The following is a description of a gene set: Human Gene Set: HP_FLAT_CORNEA studied in species Homo sapiens Cornea plana is an abnormally flat shape of the cornea such that the normal protrusion of the cornea from the sclera is missing. The reduced corneal curvature can lead to hyperopia, and a hazy corneal limbus and arcus lipoides may develop at an early age. Flat cornea, and this is the list of marker genes: RFC2, METTL27, BUD23, STX1A (NCBI Gene Id 6804), KERA, TGFB2, DNAJC30, FKBP6, TBL2, TMEM270, GTF2IRD2, ELN, MARK3, NCF1, EIF4H, VPS37D, PRDM5, CLIP2, GTF2I, RPGRIP1, BAZ1B, LIMK1, GTF2IRD1